The following is a description of a gene set: Human Gene Set: HP_SYNOSTOSIS_INVOLVING_BONES_OF_THE_HAND species: Homo sapiens Synostosis involving bones of the hand An abnormal union between bones or parts of bones of the hand., and this is the list of marker genes: ATP7A, MACROH2A1, SF3B4, EVC, NONO, MAP3K7, SALL4, NXN, FGF9, FLNB, EIF4A3, PTDSS1, PAX3 (NCBI Gene Id 5077), IHH, DYNC2LI1, PRKACA, POR, PRKACB, EVC2, FGF16, BHLHA9, HOXD13, FGFR2, GLI1, UBAP2L, ZIC1, COL27A1, TCF12, ROR2, BPNT2 (3'(2'), 5'-bisphosphate nucleotidase 2), SHH, NOG, TFAP2B, LRP4, RECQL4, FGFR3, B3GALT6 (NCBI Gene Id 126792), PITX1 (NCBI Gene Id 5307), PQBP1, APC, GDF5, LMBR1, FLNA (NCBI Gene Id 8272), TWIST1, RBM8A (NCBI Gene Id 9939), HOXA13, ESCO2, BMPR1B, ANAPC1, FBLN1, SMOC1, CHSY1, MYH3